Given this list of marker genes B9d2, Ube2q2, Tlr8, Slc12a2, Igsf23, Adcy1, Clmn, Camk2n1, Tpt1, Tenm4, Zfp277, Psip1, Otub2, Ndn, Ppfia3, Mob2, Ufl1, Cul3, Pnma2, Nol4, Eif2b2, Has1, Nr2f1, Sar1a, Tti1, Hsf1, Hk3, Cox8c, Itch, Cnr1, Sccpdh, Nutf2, Fbxo42, Btg1, Ppih, Nfib, Syne3, Zfp36l1, Nfkbid, Tenm3, Cnot6, Dnajb14, Hfm1, Erbin, Dixdc1, Tesk2, Uqcc1, Tor1b, Ctnnd1, Tlk1, Gtf3c2, Dpy19l1, Colec12, Ssr1, Ywhah (NCBI Gene Id 22629), Gabarapl2, Esco1, Pou3f3, Hoxc4, Rmnd5a, Wdr26, Zfp869, Mmp9, Slc25a3, Myo6, Wdr37, Sall1, Tmed7, Slit2, Zbtb18, Ptpn9, here is a description of the gene set: species: Mus musculus from publication Chen Y, Wang X (PMID 31504780) Genes predicted to be targets of miRBase v22 microRNA mmu_miR_455_3p in miRDB v6.0 with MirTarget v4 prediction scores > 80 (high confidence targets). Mouse Gene Set: MIR_455_3P